Given this list of marker genes Cpne4, Gprin1, Nop56 (NOP56 ribonucleoprotein), Mapk8ip2, Fam78a, Cacng2, Calb1, Eif4a2, Gm22489, 1110018N20Rik, Mir22, Gas5, Mir7b, Mir290a, H1f1, Kcnb1, Gtf2a1, Sez6l2, Zbtb37, Gm23212, Rnu11, Grm2, Zfp607b, Mir132, Slc39a3, Mgrn1, Gm23201, Gtf3c6, Cacng3, Hexim1, Asphd1, Snord3a, Sez6, Bdnf, Cyp51, Nefh, Snord110, Disp2, Unc13a, Fam163b, Chka, Vgf (VGF nerve growth factor inducible), Barhl1, Snord60, Scg3, Gm22357, Scgn, Cyb5r4, Grik5, Scamp5, Znfx1, Lhx3, Snord118, Tph2, Mir212, Traf7, Rcc1, Tsr3, Polr2a, Scrt1 (NCBI Gene Id 170729), here is a description of the gene set: Genes containing one or more binding sites for (Hira) in their promoter regions (TSS -1000,+100 bp) as identified by GTRD version 20.06 ChIP-seq harmonization. species: Mus musculus from publication Yevshin I, Sharipov R, Kolmykov S, Kondrakhin Y, Kolpakov F (PMID 30445619) Mouse Gene Set: HIRA_TARGET_GENES